The following is a description of a gene set: studied in species Mus musculus Mouse Gene Set: GOBP_BARBED_END_ACTIN_FILAMENT_CAPPING The binding of a protein or protein complex to the barbed (or plus) end of an actin filament, thus preventing the addition, exchange or removal of further actin subunits., and this is the list of marker genes: Evl, Capzb, Add3 (NCBI Gene Id 98171), Svil, Capg, Scin, Avil, Cracd, Cfl1, Eps8, Capza3, Capza1, Capza1b, Vill, Mtpn, Dbnl, Arpc2 (actin related protein 2/3 complex, subunit 2), Rdx, Flii, Twf2, Add2, Gsn, Vil1, Carmil1, Carmil2, Twf1, Add1, Capza2